The following is a description of a gene set: Mouse Gene Set: GOBP_EPITHELIUM_DEVELOPMENT The process whose specific outcome is the progression of an epithelium over time, from its formation to the mature structure. An epithelium is a tissue that covers the internal or external surfaces of an anatomical structure. species: Mus musculus, and this is the list of marker genes: Krt75, Nr5a1, Stat6, Cxcl12, Krt33b, Klf4, Plxna2, Ppp3ca, Stfa1, Hs3st3b1, Slc8a1, Rreb1, Ier3ip1, Chrd, Plk4, Wnt4 (wingless-type MMTV integration site family, member 4), Ripor2, Dnph1, Vangl2, Krt79, Fras1, Ajuba, Krt4, Bfsp2, Crb3, Krt10, Fa2h, Krt34, Abcc1, Palb2, Tdrd7, Adamts12, Adam7, Hdac2, Tgm2, Cat, Cep152, Gpat4, Alms1, Agap2, Evpl, Mafg, Agtr1b (angiotensin II receptor, type 1b), Arid4a, Ppp2r3a, Agt, Fat4, Smarca1 (SWI/SNF related, matrix associated, actin dependent regulator of chromatin, subfamily a, member 1), Cps1, Yap1, Bcr, Bmpr2, Pih1d1, Umod, Ccdc88c, Rest, Wnt7b, Sh3bp1, Axin2, Kdf1, Dsc1, Dll4 (NCBI Gene Id 54485), Pecam1, Krt78, Sprr2k, Enam, Scx, Zfp703, Ldb2, Sfrp1, Tfap2b, Fndc3a, Pla2g10, Mfsd2a, Phgdh, Acadvl (NCBI Gene Id 11370), Cplane1, Ptpro, Vegfc, Stk4, Tsc2, Lamc1, Krt5, Tomt, Pgk1, Pkp3, Krt85, Dmd, Asxl1, Edar, Kprp, Epas1, Tgm1, Zeb2, Sprr2g, Gsdme, Il10, Edaradd, Osr1, Col2a1, Nfe2l1, Irx3, Rap1b, Asb2, Elmod3, Fgf10, Cstdc4, Dmbt1, Foxp1, Traf6, Iqgap1, Pax2, Magi2, Cstdc5, Nog, Nherf1, Sprr2i, Ngfr, Gja4, Ripply1, Tollip, Foxq1, Stil, Krt20, Neurog3, Ces1h, Wwtr1, Barx1, Rab23, Chd7 (NCBI Gene Id 57137), Pelo, Adamtsl4, Pkd1, Krt6a, Kcnq1, Aldoc, Pou4f3 (POU domain, class 4, transcription factor 3), Foxd1, Gatad2a, Ptk7, Gas1 (growth arrest specific 1), Zic2, Socs3, Sprr3, Fndc3b, Krt32, Krt74, Sox17, Cd24a, Wnt9b, Krt39, Rarb, Ilk, Itgav, Ncoa3, Myf5, Kdm6a, Tagln, Rara, Tsc1, Whrn, Fam20c, Grem1, Gata4, Foxa1, Pml, Fzd5, Cyp26b1, Klf5, Cysltr1, Aqp1, Slc39a12, Krt33a, Atm, Gata5, Cers3, Pals1, Ikbkb, Wdr19, Inhba, Vil1, Dsg4, Tead2, Grb2, Spred3, Foxf1, Krt36, Eppk1, Men1, Tmprss13, Sec24b, Smad4, Ift52, Cux1 (cut-like homeobox 1), Tgm3 (transglutaminase 3, E polypeptide), Pdx1, Aldh1a3, Fzd2, Clrn1, Alox12b, Pcdh8, Zdhhc21, Wdr1, Hif1a, Ccm2, Marveld2, Ctsb, Casr, Fgf2, Spag6l, Sema4c, Icam1, Mir205, Hdac1 (NCBI Gene Id 630524), Spink5, Nphs2 (nephrosis 2, podocin), Hoxa11, Creb1, Gata2, Cysrt1, Dlg3, Runx3, Gstk1, Add1, Itga2, Minar2, Fzr1, Tnfrsf1a, Cobl, Nup50, Norad, Sfrp5, Id3, Tbc1d32, Wnt6, Nf1, Dvl1, Cthrc1, Map1b, Dag1 (dystroglycan 1), Tmem135, Onecut2, Hoxa13, Gal, Cimap3, Slc39a7, Cdh5, Rnase10, Hoxd11, Lrp2, Nfib, Lsr, Ces1f, Cgn, Lgr5, Slc9a4, Clcn2, Mcidas, Pard3, Bcl2, Pspn, Sox8, Pfn1, Ntn1, Nphs1, Gm5414, Gdf11, Rdh10, Tbx6 (T-box 6), Cdkn1a, Msgn1, Map3k1, Akt1, Rcn3, Rhob, Tcf15, Pthlh, Acat1, Id2, Prox1, Mapk1, Cbfa2t2, Shank3, Lzts2, Atoh8, Fer, Lrp4, Sfrp2, Bbs4, Foxa2, Ferd3l, Stk3, Naglu, Sprr2f, Strc, Commd5, Pgf, Plxna4, Ncor2, Stard13, Pbrm1, Bdh2, Pou2f3, Pias4, Gorab, Agtr2, Dusp10, En1, Rnf207, Crhr2, Cnmd (chondromodulin), Krt9 (NCBI Gene Id 16674), Fzd3, Cxcl10, Magi1, Kif26b, Ccdc39, Smad1, Mir203, Kat2a, Hydin, Jmjd1c (jumonji domain containing 1C), Epcam, Krt27, Mmp14, Nme2, Csta1, Mmp2, Bmpr1a, Smad2 (NCBI Gene Id 319898), Sfrp4, Tbx5, Gdf7 (NCBI Gene Id 238057), Il1a, Hes1, Atrx, Kdm2b, Cxcr4, Ppl, Hdac3 (NCBI Gene Id 15183), Vsig1, Tbx4, Prickle1, Ttbk2, Mir96, Hoxb5, Fosl2, Enah, Car2, Apold1, Trpv1, Kif20b, Ajap1, Psapl1, Mef2c, Trpc4ap, Inka1, Hapln2, Ush1c, Cdkn2a, Sprr1b, Tgfb1i1, Sema3a, Lhfpl5, Lrp5, Dnaaf1, Sufu, Traf3ip1, Pls1, Meox2, Stx2, Fzd6, Itgb5, Rspo3, Podxl, Ifitm1, Kat5, Ptgs2, Bccip, Ret, Ift57, Ercc2, Foxj2, Spred2, Bdnf, Elovl1, Ldb1, Prlr, Ccno, Tjp1, Twist1, Mrtfa, Cc2d2a, Mir875, E2f7, Cfh, Pter, Pum2, Ipmk (NCBI Gene Id 69718), Sos1, Mir7-2, Pdgfb, Hand2, Notch4, Acvr2b, Wnk4, Cdc42, Fgfr1, Eya1, Sostdc1, Ros1, Arhgap35, Cluap1, Rtn4, Tnc, Llgl2 (LLGL2 scribble cell polarity complex component), Mgp, Pdcd10, Ssbp3, Arg2, Gja5, Robo2, Tmigd1, Ctnnd1, Spdef, Ep300, Ces1a, Macroh2a2, Sult1b1, Krt87, Fzd4, Dkk1, Upk1a, Gja1, Hs3st3a1, Basp1, Sall4, Eda, Stat1, Hmga2, Abcc2, Ugcg, Zmpste24, Cnn3, Smarca4, Gsdmc2, Adrm1, Krt71, C1galt1, Btg1, Itgax, Fzd1, Nrbp1, Emx1, Hes3, Nfkbiz, Prom1, Nfix, Bad, F2rl1, Pou3f1, Slc44a4, Ski, Afdn, Orai1, Epo, Tead1, Gsta3, Nup210l, Sprr2b, Tacstd2, Plxna1, Aldh1a1, Ovol1, Foxl2, Slc22a1, Kank2, Areg (NCBI Gene Id 11839), Aloxe3, Rilpl1, Myo5a, Ednrb, Tmem132e, Rasip1, Cstdc6, Tbx2, C2cd3, Camsap3, Maf, Gli2, Slc39a2 (NCBI Gene Id 214922), Greb1l, Foxn4, Lgr4, Bax, Gli3, Tjp3, Mdk, Gfi1, Fshr, Tmed2, Ehf, Ddr1, Kdr, Cryaa, Ppp1ca, Nkx6-1, Ednra, Map2k1, Flt1, Apaf1, Vhl, Pten, Plcb1, Ptch1, Tgfbr1, Cep290, Perp, B4galt1, Pck1, Tmem79, Cldn5, Atp2b2, Mir541, Tmeff2, Myo9a (NCBI Gene Id 319681), Rdx, Serpine1, Wdr83, Insm1, Ryr2, Calb1, Pax3, Ambra1, Epb41l5, Clrn2, Fgfr2 (NCBI Gene Id 20946), Percc1, Tmem38b, Foxi3, Bmp6, Adipoq, Smarcb1, Smad7, Hgf, Dlg5, Cdkn1b, Elf5, Arhgap12, Stox1, Esrp2, Xrcc2, Mansc4, Krt86, Hoxb2, Sulf1, Tpp1, Akap9, Wnt9a, Krt26, Jun, Wnt2b, Trp73, Zfp36, Sox9, Vegfa, Prdm1, Stc1, Rap2c, Krt28, Cdh3, Vdac1, Ppp1r16b, Gli1, Fgf8 (NCBI Gene Id 14179), Sall2, Lats1, Wnt10a, Lmo4, Grhl3, Krt31, Hey1, Foxb1, Bfsp1, Myc, Ezr, Il6st, Ascl5, Spint1, Smo, Ggt1, Nkx2-2, Brpf1, Gdf6, T, Stfa2l1, Flna, Cdh2, Ift172, Sall1, Wnt16, Fn3k, Krt72, Tfcp2l1, Fgf20, Krt76, Exoc5, Rbbp6, Iqgap3, Wnt5b, Nkd1, Ces1c, Dnase1l2, Rala, Msx2, Bcl11b, Lfng, Plet1, Krt73, Adamtsl2, Ctsh, Lamb2, Rock2, Gprc5d, Nfatc1, Sema3e (sema domain, immunoglobulin domain (Ig), short basic domain, secreted, (semaphorin) 3E), Alg10b, Brd2, Fgfr4, Barx2, Lif, Ces1e, Cftr, Spry1, Pou3f2, Reg1, Tmod1, Mysm1, Sod1, Cav1, Tmtc3, Tbx1, Prkacb, Myo3b, Wnt7a, Bhlha15, Pcna, Acvrl1, Wnt11, Gzf1, Gcm2, Pax6, Scel, Rilpl2, Dsp, Zdhhc7, Rptor, Tulp3, Tcf21, Lama1, Opn3, Deup1, Nrarp, Apcdd1, Pparg, Cdkn1c, Rpgrip1l, Scrib, Clic5, Extl3, Irf6, Ezh2, Krt23, Cecr2, Slit2, Casp8, Foxc2, Jag2, Mical2, Pax8, Sharpin, Stmn1, Six3, Dab2, Igfbp5, E2f8 (E2F transcription factor 8), Smad9, Tgfb2, Ivl, Upk2, Rbbp9, Abi1, St14, Krtap6-2, Gna13, Krt17, Pdpn, Snai2, Tbc1d20, Cep63, Slc4a7, Sprr2d, Zfp36l1 (NCBI Gene Id 78714), Cldn3, Rfx6, Myadm, Src, Ndp (NCBI Gene Id 236713), Sox10, Trim71, Tbx18, F11r, Zeb1, Mir450b, Krt16, Setdb2, Zic5, Ift74, Zfp750, Frzb, Msi1, Hey2, Gak, Cfc1, Bmp7 (bone morphogenetic protein 7), Krt81 (keratin 81), Ophn1 (NCBI Gene Id 94190), Pde4d, Mesp2, Dvl2, Spred1, Cyp1a1, Akr1b1, Crhr1, Triobp, Rheb, Egfr, Foxh1, Cldn4, Esrp1, Skint1, Hrnr, Fermt1, Dicer1, Greb1, Arhgap24, Mfsd12, Hsf4, Ift80, Acta2, Fem1b, Lbx1, Irx2, Il1b, Ush2a, Mycl, Mir503, Krt42, Maff, Itga5, Sfn, Pax1, Ppp3r1, Madcam1, Itga4, Slc22a6, Mecom, Tsg101, Cd109, Nr3c1, Hs2st1, Krt19, Neurod1, Cxcr2, Flg2, Igf1, Krt15, Trps1, Dmrt1, Foxe1, Tctn1, Ccdc103, Cited2, Sdc4, Pygo2, Grxcr1, Hoxa7, Tecta, Gdf3, Vim, Etv2 (NCBI Gene Id 14008), Tgif1, Dlg1, Cdsn, Ntf5, Wnt5a, Ar, Frem2, Enpp1, Ext1, Ubn1, Rab10, Atoh1, Notch2, Lias, Vdr, Rgma, Wnt10b, Pcnt, Scnn1b, Ces1d, Npnt, Krt83, Aplnr, Six4 (sine oculis-related homeobox 4), Ren1, Mcoln3, Tnf, Sprr4, Mycn, Robo1, Krtap6-5, Gmnc, Abcb1a, B9d1, Nppc (natriuretic peptide type C), Trim28, Gsc, Nfatc3, Dlx6, Agtr1a, Rac1, Tek, Mthfr, Lrp6, Meox1, Plod3, Hoxb4 (NCBI Gene Id 15412), Asah1, Rock1, Cd151, Mmp12, Id1, Kdm2a, Ttn, Dsg2, Clock, Cdk1, Fkbp8, Foxe3, Pik3cd (NCBI Gene Id 78494, phosphatidylinositol-4,5-bisphosphate 3-kinase catalytic subunit delta), Tie1, Ovol3, Frmd6, Abcb1b, Hoxa5, Prkaca, Ccn1, Actg1, Nsdhl, Safb2, Krt90, Krt6b, Flg, Tigar, Specc1l, Ovol2 (ovo like zinc finger 2), Esr1, Pou3f3, Hbegf, Nr5a2, Nsun2, Coq7, Slitrk6, Irx1, Cnfn, Ptprs, Shroom3, Anxa4, Six2, BC028528, Chuk, Lin7c, Pak1, Abl2, Tfap2c (transcription factor AP-2, gamma), Apela, Lats2, Krt13, Pax4, Flvcr2, Errfi1, Wnt2, Rab25, Myo6, Myd88, Stat5a, Hectd1, Map7, Tst, Glmn, Lhx1, Wnt1, Spint2, Adm (adrenomedullin), Fgf7, Krt40, Intu, Arid4b, Macroh2a1, Foxn1, Myo7a, Tmc1, Rad51b, Upk1b, Nkx6-2, Nrg1, Wt1, Tcf7l2, Epor, Krt1, Epha4, Wdpcp, Pgr, Myo3a, Tubb5, Rfx3, Cfl1, Plxnb2, Map3k7, Sipa1l3, Timeless, Dlx3, Klf7, Ece1, Ctnnbip1, Csta3, Foxj1, Hdac5, Nphp3, Hes5, Krt82, Foxp2, Gata3, Dlx5, Mafb, Gpx1, Frs2, Akp3 (NCBI Gene Id 11648), Arid1a, Tmem107, Ift20, Pitx3, Mthfd1, Cyp7b1, Foxf2, Sox11, Krt12, Bsg, Prss8, Lbx2, Ptgs1, Fam3c, Loxl3, Cav3, Tmem231, Efnb2, Mib1, Gsdma3, Taf10, Tcf7, Wnt3a, Rhoc, Dact1, Smad3, Ccl11, Cpt1a, Sox21, Phactr4, Nkx3-1, Msx1, Tyms, Fuz, Ubiad1, Pphln1, Reg3g, Pdgfa, Fasn, Arx, Klk14, Jhy, Csta2, Sapcd2, Upk3a, Xbp1, Ror2, Ripply2, Tbx20, Atf4, Lcn2, Pkhd1, Kcnma1, Kazn, Atp7a, Spry2, Ampd2, Rps7, Sprr2e, Pof1b, Fat1, Sult2b1, Nphp1, Tagln2, Tgfbr2, Kdm6b, Klf15, Fgfr3, Gata6, Celsr1, Hpn, Thrb, Hoxb7, Jak2 (Janus kinase 2), Carmil2, Tgfbr3, Flnb, Rspo2, Mthfd1l, Slc9a2, Tprn, Abi2, Serpine2 (serine (or cysteine) peptidase inhibitor, clade E, member 2), Keap1, Foxp3, Csmd1, Gm5478, Tmprss11f, Brsk2, Onecut1, Csnk2b, Reg3a, Crlf1, E2f4, Cer1, Jag1, Snai1, Sox4, Ccdc40, Otp (orthopedia homeobox), Lbh, Zic3, Foxp4, Mir216a, Bmp2, Runx1, Gdf2, Gata1, Skil, Ascl3, Cldn13, Vezf1, Tgfb1, Klf2, Klhl3, Sim1, Ctsz, Krt84, Fst, Fzd7, Get1, Eng, Bcl10, Grxcr2 (glutaredoxin, cysteine rich 2), Plxnd1, Il18, Krit1, Map2k2, Ncor1, Crygb, Plaur, Aire, Il17a (NCBI Gene Id 16171), Gdnf, Tjp2, Mir874 (NCBI Gene Id 100124491), Krt35, Dkk4, Heyl, Esr2, Poglut1, Vcan, Numa1, S1pr1, Psen2, Dll3, Trp63, Amotl2, Mir7-1, Med12, Abl1, Sirt6 (sirtuin 6), Egf, Hpse, Krt24, Megf8, Tradd, Hoxb13, Fstl1, Cplane2, Slc40a1, Ntrk1, Med1, Grsf1, Pcdh15, Ces1g, Slc4a5, Smad6, Prkdc, Lncpint, Dspp, Alox12, Lce1a2, Vasp, Tnfrsf19, Actb, Ahr, Fkbpl, Hoxc13, Zfp568, Cdhr2, Igf1r, Sox18, Alox8 (NCBI Gene Id 11688), Zfp800, Pkd2, Sdc1, Fmn1, Met, Lce1g, Cdh23, Krt14, Sprr2h, Nkx2-5, Robo4, Pafah1b1, Tnmd, Arl13b, Sprr1a, Deaf1, Cd63, Noto (NCBI Gene Id 384452), Ctnnb1, Flrt3, Nckap1, Hsd17b4, Col4a1, Col5a1, Psap, Slc38a8, Crb2, Aimp2, Opa1 (OPA1, mitochondrial dynamin like GTPase, NCBI Gene Id 74143), Clasp2, Etv5, Ascl1, Ankrd24, Ttc8, Btrc, Ceacam1, Lhx2, Phb2, Lrg1, Gpr161, Fgf3, Atp2c2, Nfatc4, Cdh1, Krt77, Tbx3, Grhl2, Nom1, Clic4, Exph5, Fermt2, Bmper, C3, Itpk1, Mks1, Hrh2, Pinc (pregnancy induced noncoding RNA), Brca2, Stard7, Loricrin, Cldn19, Nkx2-1, Nkx2-6, Ptprq, Rela, Tor1a, Tfap2a, Sav1, Ifng, Epha2, Mir375, Kcne1 (potassium voltage-gated channel, Isk-related subfamily, member 1), Apc, Krt2, Stfa3, Pdzd7, Scnn1g (NCBI Gene Id 20278), Dchs1, Luzp1, Mst1, Il31ra, Stfa2, Pde2a, Ppard, Mir216b, Setd2, Ptk6, Rarg, Myf6, Wdr77, Arhgef26, Xdh, Cby1, Hhex, Lhx3, Htt, Rbpj, Pnpla1, Ntn4, Rbm4, Vcam1, Mreg, Prkx, Rhoa, Mmrn2 (multimerin 2), Kdm5b, Lef1, Tmem94, Astn2, Kras, Sema5a, Lipa, Id4, Cd44, Cdx1, Col6a1, Nkx6-3, Gpr4, Sox3, Aldh1a2, Msn, Col18a1, Pdgfra, Rapgef3, Erbb4, Cebpb, Krt80, Pxn, Prkch, Foxa3, Epha7, Mtor, Alx4, Hhip, Grhl1, Palld, Wnt3, Cdk20, Angpt1, Ccnd1, Pax7, Aqp11, Rnf220, Cited1 (NCBI Gene Id 12705), Mmp9, Prok2, Notch1, Gnas, Pkp1, Car9, Tcap, Ift122, Tmem67, Btbd7, Ces1b, Rap1a, S1pr2, Nr0b1, Plaat1, Vax1, Rab13, Nodal, Phldb2, Dbi, Cstdc3, Hoxd13, Nr2f2, Psen1, Ahi1, Sidt2, Anxa1, Sox2, Shh, Wdr72, Crygs, Krtap21-1, Cd2ap, Atp6ap2, Nle1, Bmp4, Tshz3, Slc12a2 (solute carrier family 12, member 2), Dmrt2, Ift140, Maged1, Tmem59l, Foxc1, Dact2, Ccdc78, Fgf1, Rapgef1, Tlr9, Plec, Ripk4, Heg1, Folr1, Cdkn2b, Pck2, Bmp5, S1pr3, Tnfsf11, Rapgef2, Nup133, Ptch2, Srsf6, Mtss1, Kif3a, Ihh, Abca12, Dll1, Serpinb5, Acvr1b, Bmal1, Gbx2, Otx2, Csf1r, Cd34, Agr2, Bloc1s6, Ift88, Zfas1, Ap3b1, Sema3c, Bmi1, Krt7, Hes7, Cdk6, Mir214 (microRNA 214), Ctsd, Mesp1, Plaat3, Edn1 (NCBI Gene Id 13614), Nf2, Muc2, Myo1e, Ipo7, Gpc3 (NCBI Gene Id 14734), Etv4, Syne4, Invs, Srf, Thra, Cdx2, Mir217, Stat5b, Ercc3, Rxra, Pdpk1, Alx1, Pitx2, Hesx1, Akap11, Krt25, Pofut1, Txnip, Marcks, Pbx1, Crygd, Cyp27b1, Acer1, Lta4h, Stra6, Tmem100, Sgpp1, Npr2, Acvr1, Six1, Smad5, Ntrk3, Gba1, Il6, Vcl, Cldn1, Rbm15, Slc7a11, Dlc1, Lama5, Cebpa (NCBI Gene Id 12606), Casp3, Nrp1, Proc, Ctns, Cul7, Hnf1b, Gcm1, Hand1, Ctsl, Nkx3-2, Casp6, Csf1, Brsk1, Yipf6, Clasp1, Trp53, Dhcr7, Dzip1l, Adamts16, Mnx1